The following is a description of a gene set: studied in species Mus musculus Mouse Gene Set: GOBP_NEGATIVE_REGULATION_OF_B_CELL_ACTIVATION Any process that stops, prevents, or reduces the frequency, rate or extent of B cell activation., and this is the list of marker genes: Ctla4, Foxp3, Tyrobp (TYRO protein tyrosine kinase binding protein), Atm, Il10, Tnfaip3, Cd300a, Foxj1, Laptm5, Pawr, Ndfip1, Fcgr2b, Hmgb3, Samsn1, Inpp5d, Btk (NCBI Gene Id 215271), Bank1, Tnfrsf21, Tsc2, Casp3, Tnfrsf13b, Cd24a, Pkn1, Tbc1d10c, BC037156, Btla, Lilrb4a, Cdkn2a, Sfrp1, Lyn, Bcl6, Fas, Pten, Parp3, Id2, Rc3h1, Flt3